The following is a description of a gene set: Cluster 4: genes maximally expressed at 16 h time point during differentiation of 3T3-L1 fibroblasts into adipocytes in response to adipogenic hormones. species: Mus musculus Mouse Gene Set: BURTON_ADIPOGENESIS_PEAK_AT_16HR The molecular mechanisms that regulate cellular differentiation during development and throughout life are complex. It is now recognized that precise patterns of differentially expressed genes ultimately direct a particular cell toward a given lineage and many of these are regulated during the earliest stages of differentiation. Using a microarray-based expression analysis, we have examined gene expression profiles during the first 24 h of 3T3-L1 adipocyte differentiation. RNA was isolated at times 0, 2, 8, 16, and 24 h following stimulation of differentiation and hybridized in duplicate to high density Affymetrix microarray gene chips containing a series of 13,179 cDNA/expressed sequence tag (EST) probe sets. Two hundred and eighty-five cDNA/ESTs were shown to have at least a fivefold change in expression levels during this time course and both hierarchical and self-organizing map clustering analysis was performed to categorize them by expression profiles. Several genes known to be regulated during this time period were confirmed and Western blot analysis of the proteins encoded by some of the identified genes revealed expression profiles similar to their mRNA counterparts. As expected, many of the genes identified have not been examined in such a critical time period during adipogenesis and may well represent novel adipogenic mediators. from publication Burton GR, Guan Y, Nagarajan R, McGehee RE Jr (PMID 12137940), and this is the list of marker genes: Rad51, Ecm1, Gm4739, Abcf2, Mcm7, Hat1, Asf1b, Dnmt1, Pold1, Ly6a, Fam111a, Nap1l4, Fen1, Abcf1, Pola2, Mcm4, Ifi204, Emb, Mrpl18, Cdca7, Smc2, Rrm2, Dut, Serpina3n, Ear1, Msh6, Erdr1, Pgp, Vcan, Mcm3, Grwd1, Prps1 (phosphoribosyl pyrophosphate synthetase 1), Ifrd2, Saa3, Mcm6, Mcm5, Ddx21, Hmga1, Ass1, Snx5 (NCBI Gene Id 99195), Hells, Brip1os, Chaf1b, Cdc6